Given this list of marker genes FKBP2, CALU, CD200, TMEM243, PEA15, PRNP, ZC3H13, ATP2B1, GTF2H1, UTP14C, SNRPG, ATP6V1A, HPS5, TOR1B, SRGN, UBE2S, SS18L1, SNAPC1, NFE2L2, HOPX, NFKB1, PRMT1, LRRFIP1, TRAF1, BIK, RRAS2, ANKLE2, SLC5A3, AGO2, HSBP1, PPRC1, NUBP1, IL1B, ATF3, SERPINE2, GRAMD4, PSMD9, WNK1, SLC7A5, SERPINB2, PAQR3, SPRY1, SLC26A2, GNL2, ELF4, SACS, PSMD1, FEN1, CYCS, EEF1E1, CSTB, SENP6, UAP1, PLAGL2, CDS2, CCT5, CHSY1 (NCBI Gene Id 22856), CFLAR, ACTG1, SPRY2, ADO, PRDX3, EIF2S1 (eukaryotic translation initiation factor 2 subunit alpha), IMMT, LTBP4, MRPL19, URB2, SEC62, UBA2, SLC25A5 (solute carrier family 25 member 5), DUSP14, MBNL1, NOP56, NELFE, AP1S2, PSMD14, CASP10, EBNA1BP2, FASLG, TP53BP1, SP3 (NCBI Gene Id 6670), NOL7, MTHFD2, IPO5, SNAPC5, RHOG, TUBB2A, ZNF593, VDAC3, CD40LG, PGAM1, LYSET, LIG4, NUP160, MATK, CLIC1, NSMAF, EMG1, HNRNPF, GNG5, TRAPPC2B (NCBI Gene Id 51587), TNF, ORC4, ATP5MG, FHL2, DIMT1, GEM, GABPB1, LPCAT1, EZH2, GLS (NCBI Gene Id 51679), FEZ2, POGZ, COX17, CDK17, COPS8, EIF4A3, ZPR1, SUCLA2, FADD, RGS10, ATP1B3, PNO1, HNRNPA0, CAND1, ZNF195, TXNDC9, ADAM19, RPGR, PDCD1, VIM, ADAM17, RBM14, PEX3, CA2, NAB1, FAM98A, IER3, KIF3A (NCBI Gene Id 11127), MAP2K3, UTP18, FSCN1, IPO7, TXLNA, BAIAP2, KLHL9, TSC22D2, UMPS, TM9SF1, GFI1, IL2, YWHAE, HOMER1, PWP1, PAICS, GPX1, PLEC, BCL10, CCT4, TEX261, ZNF165, HBEGF, ZNF200, UBE2D1, MKLN1, HIVEP2, GAD1, EMP3, ZFYVE16, CHMP2A, C5orf22, IL1RAP, ZNRD2, MYDGF (NCBI Gene Id 80302), NDEL1, BCL2A1, TUBA1B, RAB22A, RPN2, PSMD7, PLP2, RP2, SRI (NCBI Gene Id 6717), EZR, WDR1, HNRNPAB, CD81, PGD (NCBI Gene Id 5226), ZNF140, ISG20L2, ARF1, BAZ2B, RRP7A, DUSP2, PRDX1, ENO2 (NCBI Gene Id 2026), SENP5, DYNLL1, PTPN22, IVNS1ABP, here is a description of the gene set: We found that a number of Tfh cells downmodulated BCL6 protein after their development, and we sought to compare the gene expression between BCL6-hi Tfh cells and BCL6-low Tfh cells. from publication Kitano M, Moriyama S, Ando Y, Hikida M, Mori Y, Kurosaki T, Okada T (PMID 21636294) Human Gene Set: GSE24574_BCL6_HIGH_TFH_VS_NAIVE_CD4_TCELL_DN studied in species Homo sapiens Genes down-regulated in BCL6 high follicular helper T cells versus naïve T CD4 cells.